Given this list of marker genes RGS16, SELL, ADAMTS8, IRF1, FCGR1BP, CCL8, OASL, CXCL8, CXCL2, IL6, SELE, ICAM1, CXCL9, CCL3, UBD, CCL2, PTX3, IL1RL1, CH25H, IL1B, FPR1, CXCL1, FCGR1A, BCL2A1, SERPINA1 (NCBI Gene Id 5265), MMP12, GZMB, FOSL1, CXCL10, here is a description of the gene set: studied in species Homo sapiens Human Gene Set: PATEL_SKIN_OF_BODY_ZOSTAVAX_AGE_70_93YO_VZV_CHALLENGE_6HR_TOP_30_DEG_UP Genes up-regulated in skin of body 6hr vs 0hr in adults (70-93) (VZV challenge) after exposure to Zostavax, time point 6H. Comment: A List of the top genes upregulated at 6 hours post VZV challenge from publication Patel NP, Vukmanovic-Stejic M, Suarez-Farinas M, Chambers ES, Sandhu D, Fuentes-Duculan J, Mabbott NA, Rustin MHA, Krueger J, Akbar AN (PMID 30247603) Background: The live attenuated vaccine Zostavax was developed to prevent varicella zoster virus (VZV) reactivation that causes herpes zoster (shingles) in older humans. However, the impact of vaccination on the cutaneous response to VZV is not known. Methods: We investigated the response to intradermal VZV antigen challenge before and after Zostavax vaccination in participants > 70 years of age by immunohistological and transcriptomic analyses of skin biopsy specimens collected from the challenge site. Results: Vaccination increased the proportion of VZV-specific CD4+ T cells in the blood and promoted the accumulation of both CD4+ and CD8+ T cells in the skin after VZV antigen challenge. However, Zostavax did not alter the proportion of resident memory T cells (CD4+ and CD8+) or CD4+Foxp3+ regulatory T cells in unchallenged skin. After vaccination, there was increased cutaneous T-cell proliferation at the challenge site and also increased recruitment of T cells from the blood, as indicated by an elevated T-cell migratory gene signature. CD8+ T-cell-associated functional genes were also highly induced in the skin after vaccination. Conclusion: Zostavax vaccination does not alter the abundance of cutaneous resident memory T cells but instead increases the recruitment of VZV-specific T cells from the blood and enhances T-cell activation, particularly cells of the CD8+ subset, in the skin after VZV antigen challenge.